Given this list of marker genes CSNK2B, PPM1G (protein phosphatase, Mg2+/Mn2+ dependent 1G), TMEM106C, NDUFS1, TRAPPC3, SRP9, FAM120A, KHDRBS1, TUFM, ATP5MC3, H2AZ1, MAP2K2 (mitogen-activated protein kinase kinase 2), GLB1, NSDHL, SEM1, SOD1 (NCBI Gene Id 6647), ATP5PD, PPT1, G3BP2, HNRNPAB, CANX, ATXN10, RAD23A, SNRPE, VPS26A, ATP5F1D, SET, ATP5PF, KXD1, MDH1, AKR7A2, VBP1, HDAC2, SRSF1, NDUFC1, HCCS (NCBI Gene Id 4307), ELOC, HADHA, PRDX3, CCT5, HSPA4, HAT1, MRPS18B, COX5A, HSPA9, PDHB, DAP, IDH3G, BUB3, UQCRC2, LYPLA1, NDUFV1, STARD7, AP3S1, PSMB2, IFRD1, HAX1, MTDH, AP2S1, HADHB, SYPL1, COPS5, ATP5PO, AHSA1 (NCBI Gene Id 10598), SDHB (succinate dehydrogenase complex iron sulfur subunit B), SSBP1, ALG8, KARS1, AFG3L2, CYCS, NDUFB3, PARK7, POP5, ACTR3, SUMO1, HNRNPA2B1, GNG5, KPNA2, RAD23B, DLD, NDUFV2, G3BP1, PSMD7, CYC1, EI24 (NCBI Gene Id 9538), here is a description of the gene set: Human Gene Set: MORF_PRDX3 Neighborhood of PRDX3 peroxiredoxin 3 in the MORF expression compendium species: Homo sapiens Neighborhood of PRDX3